Given this list of marker genes COL1A2 (collagen type I alpha 2 chain), COL3A1, LUM, COL11A1, COL28A1, COL5A3, COL27A1, COL5A2, COL2A1, COL11A2, COL1A1, COL5A1, here is a description of the gene set: Any triple helical collagen trimer that forms fibrils. species: Homo sapiens Human Gene Set: GOCC_FIBRILLAR_COLLAGEN_TRIMER